The following is a description of a gene set: species: Homo sapiens Human Gene Set: PID_FOXM1_PATHWAY FOXM1 transcription factor network from publication Schaefer CF, Anthony K, Krupa S, Buchoff J, Day M, Hannay T, Buetow KH (PMID 18832364), and this is the list of marker genes: AURKB, BIRC5, CCNB1, NEK2, CDKN2A, GAS1, CCNB2, RB1, CDC25B, XRCC1, FOS, LAMA4, CKS1B, MMP2, CENPB, CCND1, ETV5, SP1, SKP2, BRCA2, CENPA (NCBI Gene Id 1058), H2BC1, CCNA2, ESR1, MYC, CDK4, GSK3A, FOXM1, EP300, ONECUT1, CENPF, CREBBP, CDK1, TGFA, MAP2K1, CHEK2, PLK1, NFATC3, CDK2, CCNE1